Given this list of marker genes TLR2, CD14, CD36, TREM2, LBP, MAPK14, DEFB131A, RIPK2, TLR4, TIRAP, RELA, here is a description of the gene set: species: Homo sapiens Any process that results in a change in state or activity of an organism (in terms of movement, secretion, enzyme production, gene expression, etc.) as a result of a lipoteichoic acid stimulus; lipoteichoic acid is a major component of the cell wall of gram-positive bacteria and typically consists of a chain of glycerol-phosphate repeating units linked to a glycolipid anchor. Human Gene Set: GOBP_RESPONSE_TO_LIPOTEICHOIC_ACID